Given this list of marker genes Pik3r2 (NCBI Gene Id 18709), Il2ra, Shc1, Il2 (interleukin 2), Ptpn6, Il5ra, Csf2, Inppl1, Jak3, Il3 (interleukin 3), Il5, Il2rg, Csf2rb, Pik3cb, Grb2, Il2rb, here is a description of the gene set: This event has been computationally inferred from an event that has been demonstrated in another species.<p>The inference is based on the homology mapping from PANTHER. Briefly, reactions for which all involved PhysicalEntities (in input, output and catalyst) have a mapped orthologue/paralogue (for complexes at least 75% of components must have a mapping) are inferred to the other species. electronically inferred by orthology from the curated human pathway part of: Interleukin-2 family signaling; Interleukin-3, Interleukin-5 and GM-CSF signaling species: Mus musculus Reactome Pathway: Interleukin receptor SHC signaling